The following is a description of a gene set: part of: Gastrulation Reactome Pathway: Formation of axial mesoderm studied in species Homo sapiens Axial mesoderm, also called chordamesoderm, is formed by cells ingressing at the anterior end of the primitive streak. The axial mesoderm produces three types of cells, namely (from anterior to posterior) prechordal plate, anterior head process, and node-derived notochord precursors. In mouse and rat, the prechordal plate gives rise to cells in the foregut endoderm, oral endoderm, and ventral cranial mesoderm; the anterior head process gives rise to the anterior portion of the notochord; notochord precursors give rise to the remaining posterior region of the notochord. Contribution of axial mesoderm in humans is less well characterized. (<br> All these cells initially form a single columnar epithelium, the notochordal plate, that is contiguous with the endoderm. The notochordal plate then submerges into the embryo to form the tubular notochord structure. During embryogenesis the notochord not only provides physical stiffness but also produces signaling molecules such as Sonic Hedgehog (SHH) that pattern surrounding tissues. After the notochord forms, it regresses in regions where vertebrae form and expands in the perichordal disc to form the nuclei pulposi, cartilage-like discs that are interspersed with the vertebrae.<br>Formation of the axial mesoderm is initiated by NODAL signaling via SMAD2,3 proteins that interact with the FOXH1 pioneer transcription factor (inferred from the activities of mouse homologs, as described by Hoodless et al. 2001, Yamamoto et al. 2001). TEAD proteins (inferred from mouse homologs as described by Sawada et al. 2005), which are negatively regulated by the HIPPO signaling pathway, and TBXT (T, BRACHURY) (inferred from mouse homologs, as described by Lolas et al. 2014), whose expression is initiated prior to primitive streak formation, act with the SMADs and FOXH1 to activate FOXA2, which then participates in activating downstream targets such as NOTO and SHH., and this is the list of marker genes: FOXA1, FOXA2, LEF1, TCF7, TBXT, TEAD2, NOTO, YAP1, FOXH1, TEAD4, SHH, SMAD3, CTNNB1, SMAD2